Given this list of marker genes B2M, PRKCE, PDPK1, PRKCB, CD3E, VAV1, CHUK, SHC1, ZAP70, AKT1, HLA-A, CD247, CD8A, CBL, RASGRP1, CD8B, MAP3K8, CD3G, PRKCQ, NRAS, CSK, FYN, RASSF5, STIM1, RAP1A, CD80, RASGRP2, CARD11, PRF1, GRAP2, KRAS, LCK, LCP2, CD86, MAP3K14, CD28, IKBKB, TRAF6, MALT1, BCL10, PAG1, PLCG1, PTPN6, PTPRC, CD3D, LAT, IKBKG, TRPV6, PRKCA, HRAS, SOS1, GRB2, ORAI1, here is a description of the gene set: Human Gene Set: PID_CD8_TCR_PATHWAY TCR signaling in naïve CD8+ T cells studied in species Homo sapiens from publication Schaefer CF, Anthony K, Krupa S, Buchoff J, Day M, Hannay T, Buetow KH (PMID 18832364)